The following is a description of a gene set: Human Gene Set: GOBP_SPINDLE_ASSEMBLY_INVOLVED_IN_FEMALE_MEIOSIS studied in species Homo sapiens The aggregation, arrangement and bonding together of a set of components to form the spindle during a meiotic cell cycle in females. An example of this is found in Drosophila melanogaster., and this is the list of marker genes: NDC80, PTEN, TUBB8, AURKA, DDB1, DCAF13, SKA2, SKA1, SEPTIN1, FBXO5, SKA3, CCNB2